Given this list of marker genes KIAA0753, GP1BB, BMP4, KCNAB2 (potassium voltage-gated channel subfamily A regulatory beta subunit 2), BBS9, NSD2, RERE, MAX, RPGRIP1L (RPGRIP1 like), PLAA, IFT27, SUFU, TCTN2, PTEN, TMEM237, PRDM16, ABCA12, FGFRL1, MEGF8, ZNF141, PDE6D, DDX59, B9D1, CSPP1, OFD1, ARMC9, PRKCZ, MKS1, RAB23, B9D2, TTC21B, KIAA0586, DVL1, EXTL3, TFAP2B, IFT74, DYNC2I2, KATNIP, AHI1, OTUD5, TMEM138, PRKACA, CC2D2A (coiled-coil and C2 domain containing 2A), SETD5, LUZP1, ROR2, TMEM218, SHH, SC5D, CEP104, RREB1, PIBF1, C2CD3, PPP2R3C, ARVCF, CEP120, NPHP3, ARL13B, BBS1, CPLX1, PITX1, WNT5A, CCDC28B, DYNC2H1, TMEM107, DYNLT2B, CPLANE1, TCTN3, TMEM67, SKI, ARL3, KIAA0825, CTBP1, TMEM231, SCNM1, IFT140, LZTFL1, IQCE, CIBAR1, EVC, LMBR1, COMT, JMJD1C, INPP5E, LETM1, TBX1, DYNC2I1, SMOC1, TXNDC15, CASZ1, HEPACAM, GABRD, GJA8, ARL6, UFD1, DHCR7, CD96, MKKS, IFT172, CEP290, HYLS1, TMEM216, RPGRIP1, DYNC2LI1, GJA5, KIF7, HSPG2, HIRA, PDPN, WDR19, FAM149B1, EVC2, SMO, ZSWIM6, SEC24C, GLI3, BBS2, LBR, UBE4B, CBY1 (chibby 1, beta catenin antagonist), PRKACB, BBS12, TCTN1, IFT80, GLI1, FGFR2, TOPORS, MAP3K20, PORCN, PIK3CA, TOGARAM1, ZNF423, MMP23B, NEK1, SPEN, HOXD13, RAB34, CEP41, here is a description of the gene set: Duplication involving bones of the feet Human Gene Set: HP_DUPLICATION_INVOLVING_BONES_OF_THE_FEET studied in species Homo sapiens